Given this list of marker genes Cfl1, Ccl17, Ccl22, Stat5a, Fscn1, Srgn, Anxa2, Mylk, Ptpn1, Fabp5, here is a description of the gene set: Genes positively differentially expressed in cell type: eTAC (extrathymic Aire-expressing cell) upon treatment with cytokine: IL-1β in mouse lymph nodes in vivo. Mouse Gene Set: CUI_ETAC_IL1B_RESPONSE_UP Cytokines mediate cell-cell communication in the immune system and represent important therapeutic targets. A myriad of studies have highlighted their central role in immune function, yet we lack a global view of the cellular responses of each immune cell type to each cytokine. To address this gap, the authors created the Immune Dictionary, a compendium of single-cell transcriptomic profiles of more than 17 immune cell types in response to each of 86 cytokines (>1,400 cytokine-cell type combinations) in mouse lymph nodes in vivo. A cytokine-centric view of the dictionary revealed that most cytokines induce highly cell-type-specific responses. For example, the inflammatory cytokine interleukin-1β induces distinct gene programmes in almost every cell type. A cell-type-centric view of the dictionary identified more than 66 cytokine-driven cellular polarization states across immune cell types, including previously uncharacterized states such as an interleukin-18-induced polyfunctional natural killer cell state. studied in species Mus musculus from publication Cui A, Huang T, Li S, Ma A, Pérez JL, Sander C, Keskin DB, Wu CJ, Fraenkel E, Hacohen N (PMID 38057668)